The following is a description of a gene set: studied in species Mus musculus from publication Tabula Muris Consortium (PMID 32669714) Mouse Gene Set: TABULA_MURIS_SENIS_MARROW_MACROPHAGE_AGEING, and this is the list of marker genes: Anp32e, Ifitm3, Tmem160, Pdap1, Ifi30, Ftl1, Atp5f1d, Ccnd3, Trem3, Psmd4, Clic1, Lmo4, Rbm3, Tmsb10, Rrm2, Tmed9, Pkm, Txn2, Psmb3, Syf2, Bsg, Lsm4, Edf1, Ifitm6 (NCBI Gene Id 213002), Chchd10, Cirbp, Aldoa, Rpl14, Srsf9, Timm13, Elof1, Elob, Ltf, Pglyrp1, Ube2m, Mrpl51, Lamtor4, Msrb1, Mrpl58, Ptma, Tle5, Tmed3, Acp1, Selenom, Tbcb, Ncf4 (NCBI Gene Id 193645), Eif5a, Mrpl20, Emilin2, Mrpl18, Phb2, D8Ertd738e (NCBI Gene Id 52426), Psmd7, Scand1, Srrm2, Tmem208, Prelid1, Slpi, Hes6 (NCBI Gene Id 98321), AW112010, Psmc3, Cfl1, Cdkn2d, Lcn2, Atp6v0b, S100a4, Ndufs7, Pfn1, Necap2, Vcf1, Hp, Psap, Atp5mc1, Atp5if1, Eif2s2, Rpl18, Anp32b (acidic nuclear phosphoprotein 32 family member B), Ngp (neutrophilic granule protein), Hsp90aa1, Tmsb4x, Ddx39a, Slfn2, Ciao2a, Ap2s1, Psmb4, Tspo, Naa10, Aprt, Ldha, Siva1, Reep5, Cox5a, Jchain, Dbi, Rab24, Ndufb9, Psmb6, Phb1, Cd52, Parl, Arhgdib, Cycs, Ctsc, Arpc1b, Retnlg, Dmkn, Mrpl42, Mrps12, Cd24a, Rpl13, H2-DMb1, Syngr2, Chil3, Psma4, Mtdh, Bax, Arhgdia, Mcemp1, Crip1, Psmd14 (NCBI Gene Id 98839), Fcer1g, Calm1, Lamtor5, Psmb8, Ptpn1, Ndufb10, Anxa2, Fkbp2, Nubp1, Emp3, Prr13, Exosc5, Rpl13a (ribosomal protein L13A), Emg1, Tgfbi, S100a8, Hnrnpd, Smdt1 (NCBI Gene Id 69029), Map2k2, Ptpn6 (protein tyrosine phosphatase, non-receptor type 6), Camp, Chmp2a, Ifitm2, S100a9, Wfdc21, Pgp, Pim1, Exosc8, Ppp1ca, Mrps26, Tmem14c, Ifitm1 (NCBI Gene Id 68713, interferon induced transmembrane protein 1), Cyba, Nr2c2ap, Eif6, Gnb2, Degs1, Dtymk, Cyc1, Pabpn1, Nhp2, Tomm22, Spi1, Ranbp1, Ube2s, Ssna1, Ddx39b, Lgals3, Coro1a, S100a6, Snrpc, Psmc1, Snhg3, Prdx1, Ralbp1, Twf2, Tex261